Given this list of marker genes CALR, CD93, APCS, CRP, MEGF10, PTX3, C4A, C1QBP, here is a description of the gene set: species: Homo sapiens Human Gene Set: GOMF_COMPLEMENT_COMPONENT_C1Q_COMPLEX_BINDING Binding to a C1q complex, a component of the classical complement cascade.